Given this list of marker genes Spry4, Unc50, Bcl7c, Fos, Cdc37, Jagn1, Iqsec3, BC005624, Meg3, Tspan3, Bok, Adm, Krt5, Smim6, Emd, Irf8, Yy1, Tmx3, H2-DMb1, Bend5, Fam89b, Boc, Megf10, Fkbp2, Bmp2k, Gnptg, Dusp3, Pltp, Nectin3, Smoc2, Set, Il34, Rbm25, Luc7l3, Pcnp, Tceal8, Tcn2, Plekhf1, Rpgrip1l, Me2, Pxdn, Alkbh5, Ppib (NCBI Gene Id 19035), Fxyd5, Arpp19, Lgals4, Bicral, Psmd11, Rapgef1, Adgrb3, Atraid, Slc39a7, Lsm3, Sec13, Tm2d2, Kazald1, Rgs2, Ift46, Lpl, Ucp2, Pex16, Slc35b1, Dbndd2, Calm2, Micu3, Ankle2, Lrpap1, Hpgd, Oas1a, Ggnbp2, Dbp, Glod4, Prr13 (proline rich 13), Nt5c3b, Fth1 (ferritin heavy polypeptide 1), Lamtor4 (late endosomal/lysosomal adaptor, MAPK and MTOR activator 4), Tmem234, Cmtm4, Spp1, Ube2m, Tspan13, Selenow, Tex261, Ikbip, Yipf3, Dpep1, Fkbp7, Pld3, Trir, Paip2, N6amt1 (NCBI Gene Id 67768), Kmt2e, Qdpr, Pip4p1, Atp2a3, Cygb, Syf2, Pik3ap1, Snrpa, Sf3b4, Ing1, Cd302, Gtpbp1, Atp6ap1, Cmtm3, Etl4, Junb, Wdr3, Daam1, Ubb-ps, Pdlim7, Prr12, Pgrmc2, Srpx, Sult1a1, Oaz1, Skil, H2-D1, Rfc3, Erp29, Gabarapl1, Vti1a, Arf5, Mcu, Arpc3, Vdac3, Rc3h1, Ilrun, Herpud1, Mlf2, Thyn1, Cops7a, Tmem132c, Fnbp1, Cmtm7, Cyc1, Tuba4a, Sertad1, Ap4e1, Serping1, Rassf3, Shisa5, Srm, Ptp4a3, Mpv17l2, Inmt, Ndufa12, Myh10, Rhbdd2, Irag1, Col4a2, Ms4a4d, Cd68, Hax1, Atg2b, Arglu1, Nudt19, Nudc, Dda1, Prrc2b, Slc39a1, Mrpl12, Smarcc1, Ablim2, Klhl18, Zdhhc5, Tax1bp1, Cela2a, Tuba1a (tubulin, alpha 1A), B3gat3, C1qbp, Traf4, Mcfd2, Nfix, Skap1, Itm2c, Cr1l, Vezt, Atp6v0e (ATPase, H+ transporting, lysosomal V0 subunit E), Ncln, Snx3, Grwd1, Atp2a2, Ints2, Nedd4l, Wdr37, Arpc1b, Mn1, Trim37, Hspa5, Ppp1r14b, Shb, Limd1, Abhd8, Plpp1, Phlda3, Il16, Neurl4, Ubn1, Supt16, Dph3, Jag1, Sparcl1, Apod, Cbr1, Sos2, Myo1d, Akap13, Tmem107, Abl1, Dynll1, Rsad2, Selenop, Tln1, Mospd3, Tnfsf12, Pdcd2l, Mrpl34, Cars1, Ssr2, Smchd1, Clec3b, Tpcn1, Rhoc (ras homolog family member C), Aamp, Ptges3, Srsf9, Gng10, Cbx1, Ifitm2, Gpm6b, Mis18a, Mydgf, Eri3, Smim14, Txn2, Rnf216, Ccdc124, Phb2, Gcnt2, Me3, Pcyt2, Ttc9c, Pirb, Tmed3, Isca2, Ppfia1, Cd81, Ddrgk1, Tspan11, Rnf220, Armc8, Zfand6, Tcf7l2, Gpx4, Mapkbp1, Meox1, Ptprs, Atf4, Fgd5, Sdhc (NCBI Gene Id 98540), Cuta, Dynlrb1, Tsn, Zc3h18, Psmc2, Ppp1r11, Vps28, Hsp90b1, Selenom, Anxa3, Dcn, Kdelr2, Hint3, Bad, Meox2, Ndufa9, Ddx52, Cp, Ece1, Mrpl28, Mcrip1, Ubb, Smim30, Penk, Itpr1 (NCBI Gene Id 18544), Limch1, Gadd45gip1, Polr2c, Gpr146, Lamtor1, Meis2, Trappc3, Ppp1r15a, Smyd5 (SET and MYND domain containing 5), Glmp, Echs1, Ube2l3, Crebrf, Krt15, Kif1a, Gpx3 (glutathione peroxidase 3), Rigi, Gnb1, Miip, Spire2, Larp1b, 2510002D24Rik, Rbm34, Dap, Eif4ebp1, Golm1, Med1, Dnajc3, Usp28, Arl3, Arpc4, Tmem9, Nabp2, Rab4b, Ccs (NCBI Gene Id 12460), Myo9b, Cnpy4, Ube2k, Ankrd54, Tmem185b, Naa80, Tubb6, Iqgap2, Akt1s1, Tnrc6c, Zfp994, Sec11c, Rock1, Psmc1, Cldn7, Map1lc3a, Eva1b, Ppl, Jund, Rbm26 (RNA binding motif protein 26), Cpb1, Zscan26, Lyz2, Reep5, Serpine2, Tbc1d30, B4galt1, Dctn5, Wbp2, Sdf2l1, Ptma, Esam, Gstp1, Cbx3, 2900026A02Rik, Nceh1, Zfp36, Oaf, Eif1ax, Trim25, Incenp, Cotl1, Cdkn1a, Lyst, Sox2, Ap2s1, Car2, Shfl, Mmp2, Cfh (complement component factor h), Fbln7, Tmem204, Igfbp7, Emc10, Kmt2b, Gm2a, Hsd11b1, Zfp516, Iws1, Selenos, Fdps, Ctsb, Crbn, Selenok, Tgif1, Marf1, Bst2, Mrpl49, Mmp24os1, Frmd7, Emc3, Scamp4, Amotl1, Ldaf1, Atn1, Tssc4, Atp8a2, Spcs2 (signal peptidase complex subunit 2 homolog (S. cerevisiae)), Fndc3a, Ilkap, Gstt1, Cfl1, Dnaja1, Eif4e3, Igsf3, Lypd8, Sox6, Fkbp8, Chsy1, Maf1, Drap1, Kdm4b, Myh9, Laptm5, Malat1, 2310011J03Rik, Lrrc8a, Cryab, Ttc4, Ess2, Snrpc, Psmd8, Irf5, Itpripl1, Adh1, Slc4a1ap, Brk1, Ptms, Nr2f2, Mbp, Sod1, Fkbp1a, Abcc1, Dctn3, Szt2, Dmap1, Crip1, Wdsub1, Uri1, Ssr1, Prelid1, Nop16, Nsfl1c, Pdia6, Rnaseh2a, Coasy (NCBI Gene Id 71743), Uqcrc1, Nfic, Slc3a2, Sumo1, Zfp414, Kdm3b, Manf, Ndufa4l2, B2m, Fcgr2b, Tab3, Gstm1, Eif3i, Arih1, Pnp, Snapc5, Ifi35, Kdelr3, Ttf2, Vwa8, S100a6, Tns1, Cyp26b1, Tesk1, Lsp1, Pde1c, Lgr5, Rheb, Rnase4, Amacr, Capg (capping actin protein, gelsolin like), Fam53b, Txnl4a, Ptpru, Sdhaf2, G0s2, Sri, Slc25a5, Plvap, Star, Ormdl2, Zswim8, Rpl13a, Cyb5a, Ier2, Acap1, Isg20, Cst3, Rab8a, Samd4b, Mtarc2, Esd, Laptm4a, Dlgap4, Coro1b, Wdr81, Tra2b (NCBI Gene Id 52560), Scml4, Kat14, Tmem131l, Cd63 (NCBI Gene Id 98116), Zfpl1, Hes1, Copz1, Ano1, Kdelr1, Ramp2, Yeats2, Foxn2, Twf1, Dnah2, Tle5, Eif4g1, Fam8a1, Agpat5, Rcn3, Tspan17, Mau2, Srgn, Hps5, Ldb3, Lmo4, Pgls, Tubb5, Phf11d, Kdm6b, Gpr137b-ps, Rp2, Tubb2b (NCBI Gene Id 73710), Slc38a6, Cacna1s, Tmed9, Scamp3, Rab34, Spag7, Ftl1, Serpinf1, Slc9a8, Eif5a, Id3, 2310033P09Rik, Tmsb10, Clic1, Mdm4, Entpd2, Wt1os (NCBI Gene Id 98901), Zzef1, Ndrg2, Uchl3, Gid4, Myc, Wdr24, Ccdc9b, 2510039O18Rik, Cpne3, Ptpn6, Ankrd6, Srpk2, S100a16, Pdhb, Anapc11, Dnajc9, Atf3, Scn1b, Nipbl, Fzd7, Slc9a9, Setd2, Gabarapl2, Nupr1 (NCBI Gene Id 80556), Yipf1, Ccl11, 4933434E20Rik, Scand1, Ppp1r13l, Phxr4, Celf4, Adamtsl3, Vtn, Fxr2 (NCBI Gene Id 23879), Itm2b, Atr, Tcf4, Hoxb2, Taf4b, Zdhhc21, Rarres2, Pgghg, Chchd2, Tradd (NCBI Gene Id 71609), Dmac1, Bcas2, Fosl2, Scamp2, Wrn (Werner syndrome RecQ like helicase), Stxbp2, Disp3, Ifi44, Lgmn (legumain), Klf13, Naa30, Cnpy3, Ctsz, C1d, Gnaq, Als2cl, Jarid2, Fam3d, Eif3g, Adrm1, Prorsd1, Pcolce, Il11ra1, Trnau1ap, Usp42, Spry2, Ctrb1, Prelid3b, Spr, Fbxo6, Bsg, Plec, Usp7, Hsp90ab1, Nme7 (NCBI Gene Id 338485), Puf60, Cltb, Tceal9, Pdcl3, Bcar3, Yif1b, Nelfe, Lum, Nup85, Ncoa3, Dusp1, Canx, Cubn (cubilin), Acbd6, Tmed1, Tomm6, Mxd4, Dpysl2 (dihydropyrimidinase-like 2), Tax1bp3, Hnrnpa0 (NCBI Gene Id 77134), Tnfsf13b, Sod3, Gatad1, Ddt, Nfkbib, Acp6, Nsd3, Bud31, Abca8a, Ggta1, Ranbp1, Cox10, Sra1, Smarcb1, Abhd6, Yif1a, Pld2, Pfn1 (profilin 1), Cdk2ap2, Ccdc59, Cxcl1, Arhgdia, Thoc3, Mdh2, H2-T23, Ralgapa1, Mzt2, Selenot, Xbp1, Slc38a2, Cks1b, Pdlim2, Efhd2, H3f3b, Arfgef1, Vps29, Napsa, Xcr1 (chemokine (C motif) receptor 1), Helz, Fam53c, Gpatch4, Itga7, Tmem11, here is a description of the gene set: from publication Tabula Muris Consortium (PMID 32669714) Mouse Gene Set: TABULA_MURIS_SENIS_AORTA_FIBROBLAST_OF_CARDIAC_TISSUE_AGEING studied in species Mus musculus